Given this list of marker genes MAML2, SLC6A16, ZNF540, FAM86C2P, MALAT1, YPEL5, PLCG1, TSPAN18, ARHGAP30, FBXO3, SLC38A6, ATP10A, ZNF623, PWWP2A, SUMF1, BTG1, DNMT3A, SLC25A26, NFIA, LINC03009, NOG, ZBTB20, CYP4V2, ETS1, HELB, LY9, NKAPP1, MEF2A, FAM120C, ENGASE, DGKD, RGCC, WDR27, HNRNPA1, NFU1 (NFU1 iron-sulfur cluster scaffold), DHRS12, PLPP6, ADPRM, TBCEL, MARF1, RPS23, SLC4A5, NFRKB, LINC00921, EPHA4, RSAD1, ZNF91, CSAD, NKTR, ZBTB10, EPC1, AMIGO1, SETMAR, ZNF831, PBX2, GGT7, NEK9, ADAMTS17, CHD3, KIZ, MBD5, CFAP44 (NCBI Gene Id 55779), CRBN, PIAS1, GLG1, MPP7, TGFBR2, AHSA2P, LRIG2, DISP1, KAT6A, ANXA2R-AS1, SH2D3A, LINC00339, BEX4, SKAP1, DIP2B, CTSF, FHIP1B, ABCF3, ZBTB4, SERINC5, TRABD2A, PRKAG2, ACAD10, ZC3H6, EPB41L4A-AS1, CCDC180, DYRK2, SLC46A3 (NCBI Gene Id 283537), APPL2, CYB561D1, TRIM52, TCF25, OLFM2, RNPC3, TMEM220, PATJ, ITM2B (integral membrane protein 2B), RGS14, OVGP1, TSGA10, MYLK4, DENND4C, ABCC10, CTC1, TSPAN32, TTC3, XPNPEP3, TMEM259, ANO9, MARCHF6, CHMP7, SGSH, IL10RA, APBB1IP, MBNL3, RPS10, SORBS3, EVI2B, DPH7, REX1BD, PHKA2, PLA2G6, CBX7, LLGL2, ZNF419, ING5, FXN, KLHL20, C16orf54, ARHGEF9, LUC7L, CPED1, TCEA3, VWA8, MTERF4, NOL4L, STK10, GABBR1, BEX2, PHF1, KLHL9, ZDHHC17, ZNF638, SIDT1, SSTR5, SCARNA9, SIN3B, ERCC6L2, TLE4, TMEM63A, RPL9, TMEM9, PNRC1, TTN, GZMM, ZBTB38, RICTOR, PRKCA, MFSD3, ARHGAP45, RPGR, TOGARAM1, TTYH2, PLEC, VSIR, ACSS1, NDRG2, MAPK13, KDM8, KPNA5, PCED1A, MTURN, PHKB, ADGRL1, ZNF280D, CELF2, ZMYND8, MBTD1, WDR91, TSPYL1, CA5B, LINS1, BRAF, TPM2, SUPT3H (NCBI Gene Id 8464), ZNF83, PRRC2B, RPL35A, TPH1, C5, HKDC1, MIR186, ZC3H12B, TMC8, EXOC6B, ZKSCAN3, UROS, here is a description of the gene set: A simultaneous engagement of different pathogen recognition receptors provides a tailor made adaptive immunity for an efficient defence against distinct pathogens. For example, cross talk of TLR and c-type lectin signalling effectively shapes distinct gene expression patterns by integrating the signals at the level of NF-κB. Here, we extend this principle to a strong synergism between the Dectin-1 agonist, curdlan, and an inflammatory growth factor, GM-CSF. Both together act in synergy in inducing a strong inflammatory signature which converts immature DCs to potent effector DCs. A variety of cytokines (IL-1β, IL-6, TNF-α, IL-2 and IL-12p70), costimulatory molecules (CD80, CD86, CD40 and CD70), chemokines (CxCl1, CxCl2, CxCl3, CCl12, CCl17) as well as receptors and molecules involved in fugal recognition and immunity such as Mincle, Dectin-1, Dectin-2 and Pentraxin 3 are strongly up-regulated in DC treated simultaneously with curdlan and GM-CSF. The synergistic effect of both stimuli resulted in strong IKBα phosphorylation, in its rapid degradation and in enhanced nuclear translocation of all NF-κB subunits. We further identified MAPK ERK, as one possible integration site of both signals, since its phosphorylation was clearly augmented when curdlan was co-applied with GM-CSF. Our data demonstrate that the immunomodulatory activity of curdlan requires an additional signal provided by GM-CSF to successfully initiate a robust β-glucan specific cytokine and chemokine response. The integration of both signals clearly prime and tailor a more effective innate and adaptive response against invading microbes and fungi. Human Gene Set: GSE32986_UNSTIM_VS_GMCSF_AND_CURDLAN_HIGHDOSE_STIM_DC_DN from publication Min L, Isa SA, Fam WN, Sze SK, Beretta O, Mortellaro A, Ruedl C (PMID 22250091) species: Homo sapiens Genes down-regulated in bone marrow-derived dendritic cells: unstimulated versus CSF2 and high dose of 1,3-beta-D-oligoglucan.